The following is a description of a gene set: Mouse Gene Set: GOCC_ACETYLCHOLINE_GATED_CHANNEL_COMPLEX species: Mus musculus A homo- or hetero-pentameric protein complex that forms a transmembrane channel through which ions may pass in response to acetylcholine binding., and this is the list of marker genes: Chrna1, Chrna6, Chrnb3, Chrne, Chrna5, Chrng (NCBI Gene Id 11449), Chrnb4, Chrnb2, Chrnd, Chrna7, Chrna9, Chrna3, Chrnb1, Chrna4, Stxbp5, Chrna2 (NCBI Gene Id 211701)